Given this list of marker genes STK39 (serine/threonine kinase 39), KCNA7, KCNA1, PRNP, AKAP7, SLC12A2, KCNK16, ADORA1, KCNMB4, KCNU1, NEDD4L, SLC9A9, NOS3, KCNIP2, SLC17A6, KCNH4, ATF4, GCK, KCNAB1, WWP2, KCNA5, KCNJ5, OPRK1, KCND2, KCNQ3, KCNJ11, KCNJ13, CAB39, TREM2, KCNK13, KCNN1, MIR212, CNGA4, KCNC1, DLG1, MIR21, SLC24A2, SUMO1, KCNJ4 (NCBI Gene Id 3761), SLC9A4, KCNH1, CD63, ATP1B4, KCNQ1, KCNH5, KCNAB2, PKD2L1, CNGA2, RGS4, ATP1A1, SLC12A9, ANO6, LARGE1, KCNMB1, OXSR1, SLC12A3, ATP1A2, KCNK10, ATP4B, GAL, FXYD5, KCNV1, KCNS1, KCNK3, ABCC8, KCNK12, ATP1B3, DRD3, DRD1, SLC9A8, GHITM, NEDD4, AKAP6, KCNH3, PTK2B, KCNE4, KCNJ6, SLC9A7, KCNA2, SLC24A5, KCNH6, KCNAB3, KCNC2, CCDC51, NOS1AP, KIF5B, LRRC38, FXYD2, SLC9A2, ATP1A3, FLNA, KEL, DPP10, SLC12A6, MCOLN3, KCNMB3, YWHAE, SLC1A3, KCNK6, ANK2, KCNA4, FHL1, CACNA1D, WNK4, DRD2, ATP1B2, KCNK1, CNGB1, VPS4B, ATP1A4, KCNMA1, KCND1 (potassium voltage-gated channel subfamily D member 1), MCOLN1, MIR26A1, KCNK4, SLC9A3, KCNG1, GNB2, KCNV2, KCNRG (NCBI Gene Id 283518), NPPA, KCND3, MIR30D, KCNH2, NSF, KCNK15, CHP1, BIN1, KCNK5, KCNA6 (NCBI Gene Id 3742), SLC17A7, ACTN2, EDN3, FXYD4, SLC12A4, LRRC52, FXYD1 (FXYD domain containing ion transport regulator 1), TSC1, SLC9C2, SLC12A5, KCNJ8, MIR29B1, HCN2 (hyperpolarization activated cyclic nucleotide gated potassium and sodium channel 2), KCNB2, ADRA2A, KCNN4, SLC24A4, SLC12A1, FXYD7, ATP4A, LRRC26, KCNC4, SNAP25, VAMP2, NOS1, FXYD6, MIR103A1, KCNJ3, KCNG4, ABCC9, KCNIP1, KCNT2, SLC9A6, KCNQ2, KCNA3, CAV3, SLC9A1, SLC9A5, KCNK2, ABCB8, KCNIP3, KCNK9, ATP12A, KCNJ15, TRPM5, TMEM38A, KCNE3, KCNB1, NALCN, PKD2, TMEM38B, HTR2A, CDKN1B, KCNN2, KCNJ12, HCRT (NCBI Gene Id 3060), HCN4 (hyperpolarization activated cyclic nucleotide gated potassium channel 4), CCT8L2, KCNS2, KCNS3, KCNJ1, KCNG3 (potassium voltage-gated channel modifier subfamily G member 3), KCNJ14, AMIGO1, KCNE1, SLC24A1, KCNJ18, HCN1, DPP6, LETM1, HPN, KCNF1, KCNE5, CDK2 (cyclin dependent kinase 2), KCNA10, KCNJ16, KCNN3 (potassium calcium-activated channel subfamily N member 3), SLC12A7, KCNJ9, KCNIP4, KCNH7, CAV1, GRP, KCNJ2, HCN3, KCNG2, KCNK7, KCNC3, SLC12A8, KCNE2, SLC24A3, TMCO3, KCNK17, TMEM175, KCNJ10, FXYD3, KCNT1, KCNH8 (potassium voltage-gated channel subfamily H member 8), SLC9C1, KCNK18, GJA5, KCNMB2, KCNQ4, GALR2, LRRC55, ANK3, P2RX7 (NCBI Gene Id 5027), AQP1, ATP1B1, KCNQ5, CASQ2, here is a description of the gene set: Human Gene Set: GOBP_POTASSIUM_ION_TRANSPORT The directed movement of potassium ions (K+) into, out of or within a cell, or between cells, by means of some agent such as a transporter or pore. species: Homo sapiens